The following is a description of a gene set: Human Gene Set: LIM_MAMMARY_LUMINAL_MATURE_UP Genes consistently up-regulated in mature mammary luminal cells both in mouse and human species. from publication Lim E, Wu D, Pal B, Bouras T, Asselin-Labat ML, Vaillant F, Yagita H, Lindeman GJ, Smyth GK, Visvader JE (PMID 20346151) INTRODUCTION: Molecular characterization of the normal epithelial cell types that reside in the mammary gland is an important step toward understanding pathways that regulate self-renewal, lineage commitment, and differentiation along the hierarchy. Here we determined the gene expression signatures of four distinct subpopulations isolated from the mouse mammary gland. The epithelial cell signatures were used to interrogate mouse models of mammary tumorigenesis and to compare with their normal human counterpart subsets to identify conserved genes and networks.METHODS: RNA was prepared from freshly sorted mouse mammary cell subpopulations (mammary stem cell (MaSC)-enriched, committed luminal progenitor, mature luminal and stromal cell) and used for gene expression profiling analysis on the Illumina platform. Gene signatures were derived and compared with those previously reported for the analogous normal human mammary cell subpopulations. The mouse and human epithelial subset signatures were then subjected to Ingenuity Pathway Analysis (IPA) to identify conserved pathways.RESULTS: The four mouse mammary cell subpopulations exhibited distinct gene signatures. Comparison of these signatures with the molecular profiles of different mouse models of mammary tumorigenesis revealed that tumors arising in MMTV-Wnt-1 and p53-/- mice were enriched for MaSC-subset genes, whereas the gene profiles of MMTV-Neu and MMTV-PyMT tumors were most concordant with the luminal progenitor cell signature. Comparison of the mouse mammary epithelial cell signatures with their human counterparts revealed substantial conservation of genes, whereas IPA highlighted a number of conserved pathways in the three epithelial subsets.CONCLUSIONS: The conservation of genes and pathways across species further validates the use of the mouse as a model to study mammary gland development and highlights pathways that are likely to govern cell-fate decisions and differentiation. It is noteworthy that many of the conserved genes in the MaSC population have been considered as epithelial-mesenchymal transition (EMT) signature genes. Therefore, the expression of these genes in tumor cells may reflect basal epithelial cell characteristics and not necessarily cells that have undergone an EMT. Comparative analyses of normal mouse epithelial subsets with murine tumor models have implicated distinct cell types in contributing to tumorigenesis in the different models. studied in species Mus musculus, and this is the list of marker genes: TANGO2, FGL1, EDEM1, ZDHHC1, SLC7A2, REEP6, SLC22A18, AQP11, BBOF1, GPRC5C, TMCO3, ALCAM, PROM2, DRC3, FOXA1, PLEKHG3, PGR, ZSCAN18, ARFGEF3, EPS8L1, TGM2, GALE, DUSP10, HSD11B2, ABCC8, NECTIN4, KLHL5, PAK4, NSD3, ERN1, ATP6V0E2, ZFHX2, MEIS3, DNAAF3, IL13RA1, MBOAT1, C1orf210, ESR1, PON3, BATF, FER1L4, SGMS1, TUBG1, SCMH1, SLC16A5, FGF13, SPRR1A, ALDH3B2, VOPP1, FBXO36 (NCBI Gene Id 130888), HMGCS2, G6PD, SORT1, TSPAN13, WNT5A, KBTBD4, HES6, HDAC11, PVALB, CACNG4, YIPF6, ABCA7, FYCO1, GMPR, PTPN6, CASZ1, TRIM6, EEF1A2, TP53INP2, CACNB3, SLC40A1, HID1, PGAP6, TSPAN1, MLPH, PHKA1, PSD4, DNAJC12, TMPRSS6, MEIS1, ACOT11, VPS33B, LNX2, WNT4, TOX3, MINDY1 (MINDY lysine 48 deubiquitinase 1), ALDH3B1, TNFSF11, ANKMY2, RABL3, FAAH, CITED1, LAMA5, RASEF, SPINK1, MYB, SPDEF, SLC44A4, WNK4, TBX3, BTRC, PRLR (NCBI Gene Id 5618), CCDC92, PXYLP1, LMNTD2, WNT7B, SLC7A4, HOXB2, H4C14, FLVCR2, GADD45G, SULT2B1